The following is a description of a gene set: species: Homo sapiens Dermatological manifestations of systemic disorders Human Gene Set: HP_DERMATOLOGICAL_MANIFESTATIONS_OF_SYSTEMIC_DISORDERS, and this is the list of marker genes: PLXND1, NKX2-6, COL1A1, MUSK, PARS2, PROP1 (PROP paired-like homeobox 1), CHRNA1, CITED2, TNFSF15, LBR, ETHE1, CPA1, CALR, DZIP1L, PKLR, LHX4, COX4I2, KCNQ2, TREX1, TMEM260, GALE, PCDH19, GTPBP3, DOK7, PALB2, MST1, SLC10A1, CTRC, MT-CYB, SLC5A7, ATP7A, SLC25A3, PRRT2, SMPD1 (sphingomyelin phosphodiesterase 1), KCNN4, ATP6AP2, RINT1, PEX5, RHD, CHRNE, IL2RG, RNASEH2B, TRMU, SCN8A, SP110, POLG2, HBG2, SCN4A, BRCA1, KRT18, RNASEH2C, COL13A1, SLC51B, NUP214, GLRX5, PFKM, IFT56, PEX14, CCDC115, ATP8B1, MED12, SPTB, PEX11B, SCN1B, TRPV6, HNF1B, AMACR (NCBI Gene Id 23600), KRAS, KLHL7, NR3C1, NR1H4, ATRX, USP8, KMT2D, FUCA1, LSM11, NAA10, BAAT, SCN9A, PEX19, GABRG2, JAK2, GSN, SLC30A10, COG7, RAPSN, LHX3, CDH23, LRP4, ENG, ABCC6, ACVRL1, TBX20, IFIH1, SYT2, KIF23, CASR, UGT1A1, SOX9, RHAG (NCBI Gene Id 6005), TLL1, CDIN1, SLC25A20, FLI1, ABCC2, SERPINA1, IL12A, TBX1, VPS33B (VPS33B late endosome and lysosome associated), POLG, ZFYVE19, PRKAR1A, GRIK2, ABCB11, PEX13, PRF1, FAM13A, DCDC2, SCO2, GALT, CTCF, VIPAS39, KCNQ3, ETFA, CASK, ELP1, RNU7-1, NPC1, SPINK1, PKHD1, SLCO1B3, CYP27A1, MUC5B, SCN1A, SLC2A1 (solute carrier family 2 member 1), PEX6, SEMA4D, COL5A1, MMP21, LIPA (NCBI Gene Id 3988), ATP11C, PEX26, ABCD3, COL5A2, EIF2AK4, KYNU, SEPTIN9, PARN, DUOX2, JAG1, ADAR, MMACHC, PAX3, SFTPA2, RBM10, IER3IP1, COQ4, PSAT1, ALG6, SPTA1, POU2AF1, VHL, PEX12, PEPD, ETFDH, SLCO1B1 (NCBI Gene Id 10599), RAB27A, GABRA1, TG, DPP9, PUS3, PEX10, SLC18A3, HBB, SLC25A13, ENPP1, TSHB, PALLD, ARMC5, DSP, NPC2, DGUOK, SAMHD1, GALK1, ARL13B, ACTC1, SPTBN1, KDM1A (NCBI Gene Id 23028), VAMP1, HTRA2, AGXT, TNPO3, SPOP, ATP6AP1, PROS1, TFAM, HMGCL, HSD17B10, STXBP2, PKD2, BRAF, KMT2E, OCLN, ALDOB, CDKN2A, RHCE, LRP5, G6PD, TP53, SEC63, LYN, SNAP25, CLDN1, SLC26A4, ATP11A (ATPase phospholipid transporting 11A), GALM, GH1, HSD3B7, PRKAG2, CHRNB1, SCN2A, TPO, FOCAD, LYST, CHRND, ZMPSTE24, MYH6, DUOXA2, RTEL1, CDAN1, HBA1, ROS1, NKX2-1, ABCB4, EIF2AK3, GPI, MYO9A, PIGA, SLC34A2, PROC, FXN, MPV17, UNC45A, RPS6KA3, CAPNS1, USP48, LPL, CPOX, EPB42, TULP3, SMAD4, AK9, SKIC3, KIF12, NBAS, NKX2-5, MYO5B, PRSS2, GNAS, SLC44A1, MMEL1, CYP7B1, SLC4A1, SEC23B, ADAMTS19, HK1, UROS, TPI1, GCLC, USP53, ATP7B, PRSS1, NDUFS4, ANK1, TSHR, CYB5A, CHAT, TERC, SH2B3, FOXE1, MVK, ACADVL, TBX19, TRHR, PCK1, CFTR, SFTPA1, ZIC3, SLC5A5, EPB41, TERT, SLC25A1, SPIB, PAX8, POU1F1, IL12RB1 (NCBI Gene Id 3594), AKR1D1, GATA6, LMNA, PRPS1, HESX1, SFTPB, GCSH, GYPC, DHFR, SFTPC, STN1, BRCA2, HLA-DRB1, PRKCSH, UNC13D, TXNDC15, SLC37A4, F5, MYH7, AGRN, PEX2, PIEZO1, RNASEH2A, EPOR, ABCA3, IRF5, DEF6, PEX1, GPR35, YARS1, ETFB, DPAGT1, ADAMTS13, IYD, PEX16, ALDOA, SLC16A2, HYOU1, TCF4, PEX3, STX11, CYB5R3, PLD1, IL18BP, CA5A, GATA4, NSD1, FCGR3B, RABL3, RNU4ATAC, IARS1, APC2, MTR (5-methyltetrahydrofolate-homocysteine methyltransferase), PTPN3